Given this list of marker genes KRTAP11-1, SIAH2, UROC1, NAT8B, TOP2A (NCBI Gene Id 7153), ARHGAP23, FAM184B, LBH, CKMT2, KRT14, S100A9, NEURL1B, PLD2, XIRP1, MALL, SOX3, CNN3, FGR, MRS2, PSMC3 (NCBI Gene Id 96121), ITGA2B, PDLIM1, TREH, GDF6, PFDN6, SPINK2, DSCAM, NR0B2, CHAT, PSMB9, SAMSN1, P3H3, PLEKHG3, CLDN18, RDH12, TMEM82, HDAC11, EVC2, CUBN, TARM1, KRT23, GNG3, PITPNM3, APOM, NDUFA8, RIPPLY3 (NCBI Gene Id 53820), APRT, FLRT1, NKX3-2, TRO, SEMA4A, H2AC4, SERINC2, TMEM51, TINAGL1 (tubulointerstitial nephritis antigen like 1), DCPS, CHRNA9, HPCAL1, RPL22, ZFYVE9, UBE2J2, SOHLH2, TMEM132B, NT5C, SGPP2, GSTP1, MVD, SOHLH1, F2RL3, CASZ1, SYNE4, GPN2, OGFOD2, CST7, KIF17, DBNDD2, TBX3, PRSS43P, SOD1, GTF2H4, RAB7A, ABHD14B, DNMT3B (DNA methyltransferase 3 beta), MIR199B, TSEN54, FGFR4, ISCA2, SYTL4, CAMKV, ERP27, BUB1B, FGF23, KRT7, ARHGAP44, TBX20, SLITRK2, MIR497, PDGFD, ZSWIM2, LMOD3, CEP112, DDX24, SLC6A7, AFAP1L2, B4GALNT2, PLEKHH2, AVP, FDX1, SPRR4, SPATA17, KCND3, ASIC5, LGI4, NRSN1, RSAD1, LHFPL1, DIO2, MIR200A, SLC34A2, COMMD3, HSH2D, STEAP2, PAX7, HDHD5, DUSP29, HEBP2, CFC1, LCMT2, EFCC1, PALM, LY6D, SFN, ALPK3, CKB, MARCO, TRIM31 (NCBI Gene Id 88008), CDKN2A, PROCA1, CIMAP1D, COL9A2, PROK2, EMX2, PTPRT, REC8, HOXC6, SNAP91, APLN, CHRNB3, GAL3ST1, SLC1A2, GPX1, CDKN3, C1QTNF2 (C1q and TNF related 2), GPR87, DNMT1, MIR326, here is a description of the gene set: Human Gene Set: GSE7568_CTRL_VS_3H_TGFB_TREATED_MACROPHAGES_WITH_IL4_AND_DEXAMETHASONE_UP from publication Gratchev A, Kzhyshkowska J, Kannookadan S, Ochsenreiter M, Popova A, Yu X, Mamidi S, Stonehouse-Usselmann E, Muller-Molinet I, Gooi L, Goerdt S (PMID 18453574) Genes up-regulated in macrophages differentiated in the presence of IL4 and dexamethasone for 5 days versus those subsequently treated with TGFB1 for 3h. studied in species Homo sapiens The goal of the study was to identify the effects of TGF-beta on primary human macrophages maturated under different conditions.